Given this list of marker genes Taldo1, Pgls, G6pdx, Tkt, Rpia, Rpe, Pgd, here is a description of the gene set: studied in species Mus musculus Pentose phosphate pathway Mouse Gene Set: WP_PENTOSE_PHOSPHATE_PATHWAY